The following is a description of a gene set: TWIK channels exhibit very low current and comprise of TWIK1, TWIK2 and KCNK7 members. TWIK current may be low due to rapid recycling of the channels from the plasma membrane. species: Homo sapiens part of: Tandem pore domain potassium channels Reactome Pathway: Tandem of pore domain in a weak inwardly rectifying K+ channels (TWIK), and this is the list of marker genes: KCNK1 (NCBI Gene Id 3775), KCNK6, KCNK7